Given this list of marker genes APOC3 (apolipoprotein C3), APOA1 (NCBI Gene Id 335), APOC2, APOA5, NR1H4, APOA2, ANGPTL3, ANGPTL4, here is a description of the gene set: Human Gene Set: GOBP_REGULATION_OF_VERY_LOW_DENSITY_LIPOPROTEIN_PARTICLE_REMODELING studied in species Homo sapiens Any process that modulates the rate, frequency or extent of very-low-density lipoprotein particle remodeling. Very-low-density lipoprotein particle remodeling is the acquisition, loss or modification of a protein or lipid within a very-low-density lipoprotein particle, including the hydrolysis of triglyceride by hepatic lipase or lipoprotein lipase and the subsequent loss of free fatty acid.